The following is a description of a gene set: The expansion of a NK T cell population by cell division. species: Mus musculus Mouse Gene Set: GOBP_NK_T_CELL_PROLIFERATION, and this is the list of marker genes: Tyk2, Myc (NCBI Gene Id 17869), Rasal3, Il15, Zbtb7b, Il12b, Jak2 (Janus kinase 2), Elf4, Il23a, Il18